Given this list of marker genes IKBKE, UBA52, UBC, LY96, UBB, RPS27A, TBK1, TICAM1, OPTN (NCBI Gene Id 337928), TANK (NCBI Gene Id 10010), TICAM2, TLR4, CD14, TRAF3, here is a description of the gene set: Production of type I IFN genes in response to Toll-like receptor 3 (TLR3) and TLR4 ligands is mediated by TANK-binding kinase 1 (TBK1) or I-kappa-B kinase epsilon (IKKε, IKBKE), which phosphorylate IFN regulatory factor 3 (IRF3) and IRF7. The activity of TBK1 and/or IRF3, IRF7 is regulated by multiple mechanisms including post-translational modifications, protein-protein interactions, and protein degradation (Zhao W et al., 2013; Runde AP et al., 2022). <br>. species: Homo sapiens Reactome Pathway: Regulation of TBK1, IKKε (IKBKE)-mediated activation of IRF3, IRF7 part of: Activation of IRF3, IRF7 mediated by TBK1, IKKε (IKBKE)